Given this list of marker genes TBC1D7, EGR2, FGGY, PDK4, SNORA64, DNAJC25-GNG10, PHACTR1, MIR221, SNORA3A, HBEGF, here is a description of the gene set: from publication Hoek KL, Samir P, Howard LM, Niu X, Prasad N, Galassie A, Liu Q, Allos TM, Floyd KA, Guo Y, Shyr Y, Levy SE, Joyce S, Edwards KM, Link AJ (PMID 25706537) Human Gene Set: HOEK_NEUTROPHIL_2011_2012_TIV_ADULT_3DY_DN species: Homo sapiens Genes down-regulated in neutrophil 3d vs 0d in adults after exposure to 2011-2012 trivalent inactivated vaccine (A/California/7/09 (H1N1), A/Perth /16/2009 (H3N2), B/Brisbane/60/2008), time point 3D. Comment: Down-regulated DE RNA transcripts (down >= 1.5x) shared between both TIV-vaccinated donors Systems biology is an approach to comprehensively study complex interactions within a biological system. Most published systems vaccinology studies have utilized whole blood or peripheral blood mononuclear cells (PBMC) to monitor the immune response after vaccination. Because human blood is comprised of multiple hematopoietic cell types, the potential for masking responses of under-represented cell populations is increased when analyzing whole blood or PBMC. To investigate the contribution of individual cell types to the immune response after vaccination, we established a rapid and efficient method to purify human T and B cells, natural killer (NK) cells, myeloid dendritic cells (mDC), monocytes, and neutrophils from fresh venous blood. Purified cells were fractionated and processed in a single day. RNA-Seq and quantitative shotgun proteomics were performed to determine expression profiles for each cell type prior to and after inactivated seasonal influenza vaccination. Our results show that transcriptomic and proteomic profiles generated from purified immune cells differ significantly from PBMC. Differential expression analysis for each immune cell type also shows unique transcriptomic and proteomic expression profiles as well as changing biological networks at early time points after vaccination. This cell type-specific information provides a more comprehensive approach to monitor vaccine responses.